The following is a description of a gene set: VEGFR3 signaling in lymphatic endothelium Human Gene Set: PID_LYMPH_ANGIOGENESIS_PATHWAY from publication Schaefer CF, Anthony K, Krupa S, Buchoff J, Day M, Hannay T, Buetow KH (PMID 18832364) species: Homo sapiens, and this is the list of marker genes: RPS6KA1, AKT1, PIK3R1, ITGA2, SOS1, MAPK11, CRK, CREB1, PIK3CA, COL1A2, MAPK14, ITGA4, ITGA5, FLT4, MAP2K4, COL1A1, MAPK3, SHC1 (SHC adaptor protein 1), MAPK1, ITGA1, ITGB1, FN1 (NCBI Gene Id 2335), GRB2, VEGFD, VEGFC